Given this list of marker genes Map2k6, Pip4k2c, Ep300, Trp53, Pip4k2a, Ing2, Pip4p1, Pip4k2b, Pin1, here is a description of the gene set: Mouse Gene Set: REACTOME_PI5P_REGULATES_TP53_ACETYLATION species: Mus musculus PI5P Regulates TP53 Acetylation